The following is a description of a gene set: species: Mus musculus Early prostate development genes (up-regulated at 12 hr dihydrotestosterone) which are also up-regulated in high grade prostatic intraepithelial neoplasia (PIN) vs invasive cancer. Mouse Gene Set: SCHAEFFER_PROSTATE_DEVELOPMENT_AND_CANCER_BOX5_UP Cancer cells differentiate along specific lineages that largely determine their clinical and biologic behavior. Distinct cancer phenotypes from different cells and organs likely result from unique gene expression repertoires established in the embryo and maintained after malignant transformation. We used comprehensive gene expression analysis to examine this concept in the prostate, an organ with a tractable developmental program and a high propensity for cancer. We focused on gene expression in the murine prostate rudiment at three time points during the first 48 h of exposure to androgen, which initiates proliferation and invasion of prostate epithelial buds into surrounding urogenital sinus mesenchyme. Here, we show that androgen exposure regulates genes previously implicated in prostate carcinogenesis comprising pathways for the phosphatase and tensin homolog (PTEN), fibroblast growth factor (FGF)/mitogen-activated protein kinase (MAPK), and Wnt signaling along with cellular programs regulating such 'hallmarks' of cancer as angiogenesis, apoptosis, migration and proliferation. We found statistically significant evidence for novel androgen-induced gene regulation events that establish and/or maintain prostate cell fate. These include modulation of gene expression through microRNAs, expression of specific transcription factors, and regulation of their predicted targets. By querying public gene expression databases from other tissues, we found that rather than generally characterizing androgen exposure or epithelial budding, the early prostate development program more closely resembles the program for human prostate cancer. Most importantly, early androgen-regulated genes and functional themes associated with prostate development were highly enriched in contrasts between increasingly lethal forms of prostate cancer, confirming a 'reactivation' of embryonic pathways for proliferation and invasion in prostate cancer progression. Among the genes with the most significant links to the development and cancer, we highlight coordinate induction of the transcription factor Sox9 and suppression of the proapoptotic phospholipid-binding protein Annexin A1 that link early prostate development to early prostate carcinogenesis. These results credential early prostate development as a reliable and valid model system for the investigation of genes and pathways that drive prostate cancer. from publication Schaeffer EM, Marchionni L, Huang Z, Simons B, Blackman A, Yu W, Parmigiani G, Berman DM (PMID 18794802), and this is the list of marker genes: Pid1, Nrep, Acer3 (NCBI Gene Id 71401), Peli2, Aspn, Ehbp1, Svil, Emcn, Plpp3, Sfrp1, Aldh1a1